Given this list of marker genes COG2, COG5, COG1, COG8, COG6, COG4, COG3, GOLGA5, COG7, here is a description of the gene set: The retrograde movement of substances within the Golgi, mediated by COP I vesicles. Cis-Golgi vesicles are constantly moving forward through the Golgi stack by cisternal progression, eventually becoming trans-Golgi vesicles. They then selectively transport membrane and luminal proteins from the trans- to the medial-Golgi while leaving others behind in the trans-Golgi cisternae; similarly, they selectively move proteins from the medial- to the cis-Golgi. species: Homo sapiens Human Gene Set: GOBP_RETROGRADE_TRANSPORT_VESICLE_RECYCLING_WITHIN_GOLGI